The following is a description of a gene set: species: Homo sapiens Malignant hyperthermia Human Gene Set: HP_MALIGNANT_HYPERTHERMIA Malignant hyperthermia is characterized by a rapid increase in temperature to 39-42 degrees C. Malignant hyperthermia may occur in response to either inhalational anesthetics such as halothane, to muscle relaxants such as succinylcholine, or to exercise., and this is the list of marker genes: SCN5A, ATP2A1, CLCF1, ABCA12 (ATP binding cassette subfamily A member 12), SCO2, CHRND, KDF1, TRAF6 (TNF receptor associated factor 6), PGM1, STAC3, MYH3, BIN1, CHRNG, SCN4A, TRAPPC9, MTMR14, MYF6, ELP1, NALCN, EDAR, EDARADD, CHRNA1, DNM2, RYR1, CACNA1S, CRLF1, HSPG2